Given this list of marker genes RN7SL124P, EPC2, RPRM, RIF1, ORC4, LINC01818, RNU6-601P (NCBI Gene Id 106479832), LINC01817, NEB, PRPF40A, ENSG00000212181, TUBAP13, KIF5C-AS1, UBQLN4P2, ENSG00000306042, RPS20P13, NUDCP1, USP12P2, ENSG00000286081, RBM43, FMNL2, MBD5, LYPD6, MIR4773-2, ATP5PBP4, USP8P2, RPL17P13, RPS29P8, FAM8A3P, TXNP5, LINC02612, DNAJA1P2, KIF5C, MMADHC-DT, TNFAIP6, ARL5A, RPL30P2, RNU2-9P, CACNB4, ARL6IP6, LINC01931, LINC01920, NMI (NCBI Gene Id 9111), FABP5P10, MIR4773-1, STAM2, LYPD6B (LY6/PLAUR domain containing 6B), GALNT13, MMADHC, ENSG00000200377, RPL23AP29, LINC01850, UBBP3, RND3, here is a description of the gene set: studied in species Homo sapiens Human Gene Set: chr2q23